The following is a description of a gene set: species: Homo sapiens Reduction in the size or volume of epiphyses. Human Gene Set: HP_SMALL_EPIPHYSES Small epiphyses, and this is the list of marker genes: RSPRY1, COMP, COL9A3, DLK1, COL2A1, MMP13, TMEM67, KIF22, EIF2AK3, SLC10A7, MEG3, AIFM1, MATN3, COL11A1, TRIP11, SLC35B2, COL9A1, RTL1, TONSL, RNU4ATAC, COL9A2, RMRP, NANS, CHST3